The following is a description of a gene set: from publication Chen Y, Wang X (PMID 31504780) Genes predicted to be targets of miRBase v22 microRNA mmu_miR_876_3p in miRDB v6.0 with MirTarget v4 prediction scores > 80 (high confidence targets). Mouse Gene Set: MIR_876_3P species: Mus musculus, and this is the list of marker genes: Ubr5, Srcap, Nucks1, Wnt11, Rala, Tmem260, Slc16a6, Psma3, Hdac7, Capn1, Med13, Coro2a, Ralgps1, Ror1, Epb41l2, Zfp800, Fgf9, Katnbl1, Zfp867, Cdh11, Arsk, Mep1a, Eeig1, Dnm3, Nlk, Abhd5, Hs2st1, Mlph, Phlpp1, Rbbp4, Egr2, Klf9, Heg1, Dlgap1, Aftph, Dpysl2, Entr1, Mfsd14a, Wnt9a, Erc2, Dtna, Wnk2, Car9, Vegfa, Kctd12b, Lrp4, Tnfsf8, Naf1, Col4a3, Galnt16, Gabpa, Cbll1, Vezf1, Kbtbd2, Vps18, Stradb, Rfx7, Ms4a10, Krtap4-7, Kat2b, Septin2, Crot, Hdac4, Tssk2, Hsd17b6, Lhfpl2, Slc36a2, Vwc2l, Cdk14, Dlg2, Psmb1, Tmem204, 4930505A04Rik, Glycam1, Npr3, Mmd, Cep350, Nog, Ptgr2, Ifit2, Mpv17, Dcun1d3, Creb3l1, Strn3, Chac2, Drd4, Msantd5f6, Bmp2, Yes1, Tgfbr1, Igfbp5, Arhgef40, Cps1, Taf9b, Vcpip1, Pdgfra, Eif4g2, Rnf19a, Ostm1, Bloc1s2, Rnf170, Sulf1, Dync1li2